The following is a description of a gene set: Human Gene Set: GOBP_POSITIVE_REGULATION_OF_ACTIVATED_T_CELL_PROLIFERATION Any process that activates or increases the rate or extent of activated T cell proliferation. studied in species Homo sapiens, and this is the list of marker genes: CD24, SLAMF1, GPAM, IL12RB1, IGF1, EPO, IL12B, PPP3CA, STAT5B, HMGB1, MIR30B, MIR21, IGFBP2, TMIGD2, IL2RA, RPS3, PYCARD, TNFSF9, IL2, STAT5A, IL23A, IGF2, IL18, HHLA2, AGER, IL23R, FADD (NCBI Gene Id 8772), ICOSLG